Given this list of marker genes HSPB1, MBD1, S1PR1, CD1D, TRIM32, HSPA2, SVBP, RAC3, ANAPC15, MFNG, SLFN13, RAPH1, SH3BP5L, CPSF1, CD5L, HELZ, ING1, PRKAR2B, GDPD1, PECR (NCBI Gene Id 55825), CPLANE1, ATL1, MYL6, GLIS3, DIPK2A, POSTN, LTC4S, GPR34, ARHGAP18, MSRB2, ZNF229, PTK2B, DISP1, MRPS33, SYNGR1, STARD9, MRPS21, CD99L2, MVB12A, NDUFA3, LAMA3, ARHGAP19, PKIB, CSK, LRSAM1, HNRNPUL1, TNC, ICA1 (islet cell autoantigen 1), SLC9A9, ENTREP3, CC2D1B, VAMP3, MLEC, HMGA2 (high mobility group AT-hook 2), TBC1D14, LRG1, PTEN, MADD, FNIP2, COPS7A, CLEC4D (NCBI Gene Id 338339), CRYZ, LPCAT2, MINDY2 (MINDY lysine 48 deubiquitinase 2), RAPGEF6, RNF14, SIAE, CCN1, RAC1, ADAP1, LSP1, RAB34, TLR3, KIFAP3, LOXL3 (NCBI Gene Id 84695), ATG2B, MAN1C1, FAM217B, MAP3K5, NELFB, RPL11, MPST, TSC22D4, VPS26C, NMRK1, SCARB1 (scavenger receptor class B member 1), GNG12, ZNF658, NGLY1, FAM3C, GALNT4, SELENOW, H1-0, GAS2L3, PTPN6, AGBL3, SH3D19, CEP131, GRAMD1A, ZZEF1, PHYKPL, WWP1, BST2, RUNDC3B, CELF1, KLHL8, TMEM18, IGKC, TMA7, ALOX5AP, MAF, P2RY13, HOXA3, EDC3, SMAGP, CEP19, GAB3, RPP21, KDSR, ULK2, PF4, SASH1, RFNG, PBXIP1, FBXW4, RASSF2, NDUFA1, SGCB, NELFA, NOD1, NEK3, LIFR, EIF5A2, CNOT6, EIF4EBP2, PDP2, GNPAT, SUSD3, SERHL2, SUCLG2, BEND4, RTEL1, ABHD14B, NFXL1, GMIP, HMOX2, B3GALNT1, DTD1, STK38, APAF1, TNRC6A, VAV3, COMMD9 (NCBI Gene Id 399879), NKIRAS2, DHX32, MAP1S, YWHAH, RAPSN, PRPS2, DGKZ, RNF19A, LAGE3, BRD9, RNPEPL1, OCEL1 (occludin/ELL domain containing 1), DDX23, TTYH3, USP22, CCND3, UQCC6, RALBP1, PAK2 (p21 (RAC1) activated kinase 2), TRIOBP, PPP1R13B, FAM107B, MRPL11, TRAF3IP3, CD180, PCBP4, SEMA4D, C1QC, BLMH, SC5D, GLTP, TUBB2B, NGDN, FLI1, GAPVD1, GPR176, MS4A6A, RNASE4, UQCR11, MAP1LC3B, KPNA3, CDC42EP3, ZC4H2, SKIL, SOD1, CERS5, SCAP, here is a description of the gene set: IL-10 or IL-6 stimulation of control 129xC57BL/6 murine bone marrow derived macrophages in the presence of LPS. We used microarrays to detail the global programme of gene expression changes in response to IL-6 or IL-10 stimulation in the presence of lipopolysaccharide. BMDMs were isolated from control, IL-6-/-, and IL-10-/- mice on a 129XBL/6 mixed background mice and differentiated in the presence of CSF-1 for 6-7 days. Cells were scraped and plated in 6 well plates at 2x10e6/well. Cells were washed with complete DMEM and rested for 1-2 hr before stimulation with combinations of IL-10 (10 ng/ml), IL-6 (2 ng/ml) or LPS (100 ng/ml) for 45 min or 180 mins. Complete biological replicates were performed. Genes up-regulated in bone marrow-derived macrophagesat 180 min of stimulation by IL10 and LPS: IL6 knockout versus IL10 knockout. from publication El Kasmi KC, Holst J, Coffre M, Mielke L, de Pauw A, Lhocine N, Smith AM, Rutschman R, Kaushal D, Shen Y, Suda T, Donnelly RP, Myers MG Jr, Alexander W, Vignali DA, Watowich SS, Ernst M, Hilton DJ, Murray PJ (PMID 17114459) studied in species Homo sapiens Human Gene Set: GSE5589_IL6_KO_VS_IL10_KO_LPS_AND_IL10_STIM_MACROPHAGE_180MIN_UP